The following is a description of a gene set: species: Homo sapiens A DNA repair process in which a small region of the strand surrounding the damage is removed from the DNA helix as an oligonucleotide. The small gap left in the DNA helix is filled in by the sequential action of DNA polymerase and DNA ligase. Nucleotide excision repair recognizes a wide range of substrates, including damage caused by UV irradiation (pyrimidine dimers and 6-4 photoproducts) and chemicals (intrastrand cross-links and bulky adducts). Human Gene Set: GOBP_NUCLEOTIDE_EXCISION_REPAIR, and this is the list of marker genes: HMGN1, GTF2H2, BRCA2, ERCC2, DPF3, POLB, USP44, SMARCE1 (NCBI Gene Id 6605), SMARCC2, SMARCC1, SMARCD3, ACTB (actin beta), ACTL6B, RPA1, ERCC3, RAD23A, XPC, OGG1, BCL7A, RPA3, RPA4, RAD23B, DDB1, USP45, UVSSA, RAD52, GTF2H3, HUS1B, GTF2H1, ACTL6A, SIRT1, POLK, PBRM1, ARID2, POLL, ERCC1, NTHL1, CUL4A, DDB2, PNKP, POLD1, KAT5, TP53, SMARCD1, BCL7B, GTF2H2C, SMARCD2, XAB2, POLE, ATXN3, USP7, HUS1, LIG4, ARID1A, HMGB1, SMARCA2, ELOF1, SLX4, SMARCA4, GTF2H2C_2, RBX1, BRIP1, ERCC4, ERCC8, POLD3, ERCC5, CETN2, GTF2H5, RPA2, FANCC, SMARCB1, DPF1, FAN1, GTF2H4, DPF2, POLA1, ERCC6, BRD7, ARID1B, POLR2I, MNAT1, SLC30A9, BCL7C, RNF111, PHF10, XPA, KAT7, COMMD1